The following is a description of a gene set: from publication Yevshin I, Sharipov R, Kolmykov S, Kondrakhin Y, Kolpakov F (PMID 30445619) Mouse Gene Set: CGAS_TARGET_GENES Genes containing one or more binding sites for (Cgas) in their promoter regions (TSS -1000,+100 bp) as identified by GTRD version 20.06 ChIP-seq harmonization. studied in species Mus musculus, and this is the list of marker genes: Alk, Cux1, Gm11696, Mllt10, Sdk2, Gm13136, Sh2d3c, Rbm47, Tdg-ps, Or4k40, Gm15295, Rbfox3, Gabrg3, Tbl1xr1, Gm4799, Papolb, Rps2-ps13, Kcnn3, Otud5, Gm7278, Gm7162, Vwa8, Arhgef1, Cdk19, Gm12449, Ermp1, Xlr4c, Rhbdl1 (rhomboid like 1), Gm13238, Gm15867, Gm6311 (predicted gene 6311), Akirin1-ps, Vmn1r50, Gm16599, Dab1, Phyhipl, Kcnj15, Fgd1, 4930517L18Rik, Gm5597, Ybx1-ps2, A330102I10Rik, Gabbr2, Gjd2, Gm14928, Gm11687, Pgap4, Gm9260 (predicted gene 9260), Gramd1a, Serpinb6e, Gm7341, Gm13241 (predicted gene 13241), Gm13231, Zbtb37, Nisch, Pikfyve, Me2, Rasef, Gm9964, Met, Usp29, Shisa4, Unc5c (unc-5 netrin receptor C), Fgf13, Gm7153, Msh4, 4732440D04Rik, Akt1s1, Ikbkg, Igsf3, Fam83b, B230119M05Rik, Fbln1, Idh1, Gm12428, Med12l, Gm8495, Hs6st2, Gm13884, Card10, Map2k4, Ivl, Rb1cc1, Ttc9, 1110018N20Rik, A330048O09Rik, Ptbp3, Abhd17a, Reps2, Sult2b1, Cdh24, Gars1, Smarca5-ps, Ddx4, Mecp2, Runx1, Gm2464, Sub1, Dpm1, Gabre, Gm11240, Mtcl2, Or2z8, Otulinl, Gm16425, Ddah1, Topaz1, 2310026I22Rik, She, Atxn2l, Armcx4, Nhs, Gm6568, Mir6991, Gm15165, Gjd2os, Klhl38, Il9r, Gm4459, Mas1, Kcnk6 (potassium inwardly-rectifying channel, subfamily K, member 6), Cited1, AA414768, Ace2, Ptgfrn, Zfp616 (NCBI Gene Id 327963), Ano4, Otx1, Gm14634, Prdm16, Gm28050, Cnn3, Pdk3, Gm26679, AU022252, Gm2136, Gm13140, Cfap20dc, Gm26224, Lonrf2 (NCBI Gene Id 98460), Gm16437, Rpl23a, Clstn2, Kat2b-ps, Hsf5, Mast1, P3h1, Galnt13, Gm15173, 1700071K01Rik, Nefh, Gm13135, Ttyh1, Bri3, Hrh3 (NCBI Gene Id 99296), 4933428G20Rik, Taf11, Gm20474, Ctxnd1, 4930455B14Rik, Rnf26rt, 9430021M05Rik (RIKEN cDNA 9430021M05 gene), Adad1, Dmrtb1, Gm14127, Bspry, Wscd2, Gm9962, 3110070M22Rik, Gas5, Dlgap1, Mir219a-2, Wmp, Palm3, Nrxn2, Gm6433, Prr23a1, Gm8641, Gm15688 (predicted gene 15688), Gm13217 (predicted gene 13217), Gm4204, Rtl6, Ikzf3, Zfx, Tmem267 (NCBI Gene Id 633640), Lrrc8d, Dst, Rab1a, Sh2b3, Gm15784, Chrd, Gse1, Fbxl19, Zmiz1, Gm13034, 2500002B13Rik (NCBI Gene Id 78353), 8030474K03Rik, Taf9b, Lonrf3, Tom1l2, Kcnma1, Gm26725, Rps6ka3, Cnot2, Mbnl3, Tmc7, 1700067K01Rik, Gm13146 (NCBI Gene Id 384087), Ppl, Cldn34c4, 6330409D20Rik, Gm12128, Suv39h1, Dgki, Kansl1l, Gsx1, Cys1, Aldoa, Kcng2, Coil, Eva1b, Nup210